The following is a description of a gene set: Cytokines mediate cell-cell communication in the immune system and represent important therapeutic targets. A myriad of studies have highlighted their central role in immune function, yet we lack a global view of the cellular responses of each immune cell type to each cytokine. To address this gap, the authors created the Immune Dictionary, a compendium of single-cell transcriptomic profiles of more than 17 immune cell types in response to each of 86 cytokines (>1,400 cytokine-cell type combinations) in mouse lymph nodes in vivo. A cytokine-centric view of the dictionary revealed that most cytokines induce highly cell-type-specific responses. For example, the inflammatory cytokine interleukin-1β induces distinct gene programmes in almost every cell type. A cell-type-centric view of the dictionary identified more than 66 cytokine-driven cellular polarization states across immune cell types, including previously uncharacterized states such as an interleukin-18-induced polyfunctional natural killer cell state. Mouse Gene Set: CUI_T_CELL_CD8_IL7_RESPONSE_DN species: Mus musculus Genes negatively differentially expressed in cell type: CD8+ T cell upon treatment with cytokine: IL-7 in mouse lymph nodes in vivo. from publication Cui A, Huang T, Li S, Ma A, Pérez JL, Sander C, Keskin DB, Wu CJ, Fraenkel E, Hacohen N (PMID 38057668), and this is the list of marker genes: Neurl3 (NCBI Gene Id 76530), Kif21b, Neat1, Atp1b3, Il7r, Tcf7 (NCBI Gene Id 21414), Sptbn1, Utrn, Cmah, Zfp36l2, Slc12a7, Cox7a2l, Cd3g, Actn1, Fos, Lsp1, S100a10 (S100 calcium binding protein A10 (calpactin)), Add3, Uqcrh, Ptpn22 (protein tyrosine phosphatase, non-receptor type 22 (lymphoid)), AB124611, Smc4, Evl, Stim1, Tnrc6b, Kmt2e, Ighm, Dap, Trp53inp1, Acp5, Cxcr4, Ipcef1, Scml4, Tsc22d3, Paip2, Rasgrp2, Pik3r1, Klf3, Fam78a, Rsrp1, Zbtb20 (zinc finger and BTB domain containing 20), Gmfg, Hspa1b, Hcst, Srgn, Gramd1a, Uba52, H2az2, Stk38, Ypel3, Crlf3, Pik3ip1, Arhgap45, Madd, Mxd4, Btg1, Top2b, Klf2, Rgs10, Kdm7a, Pold4, Tdrp, Arl5c, Sh2d1a, Cnot6l, Foxo1, Pdcd4, Tmem71 (NCBI Gene Id 213068), Celf2, Clk1, Fyb1, Rflnb, Rnf167, Cirbp, Jun, Gpx4, Tent5a, Txnip, 9930111J21Rik2, Ccr9, Adcy7, Saraf, Btg2, Crip1, Npc2, Hp1bp3, Arhgef18, Klhl24, Jak1, Stk4, Ctla2a, Srpk2, Eef2, Hspa1a (NCBI Gene Id 193740), Smpdl3a, Bnip3l (NCBI Gene Id 97931), Dapl1, Cd28, Gimap6, Myh9, Cd7, Stap1, Arhgef1, Creb1, Klrd1, Gpr174, Map4k4, Adgre5, Tspo